Given this list of marker genes DGUOK, DHFR2, DTYMK, ADA, TK1, DERA, DPYD, XDH, GDA, TK2, PNP, here is a description of the gene set: The chemical reactions and pathways involving any one of a family of organic molecules consisting of a purine or pyrimidine base covalently bonded to a sugar deoxyribose (a deoxyribonucleoside). species: Homo sapiens Human Gene Set: GOBP_DEOXYRIBONUCLEOSIDE_METABOLIC_PROCESS